Given this list of marker genes PEX2 (peroxisomal biogenesis factor 2), NSUN2, B3GAT3, SLC35A2, B3GALT6, ZBTB20, WDR26, DHCR24, MEG3, NALCN, GUSB, FGD1, SOX9, UBE3B, FIG4, FGFRL1, TNNT3, TNNI2, TRPV4, MYH8, CHST3, VAC14, RAB23, DDR2, RAB3GAP2, SLC26A2, FBN1, SH3PXD2B, ZFX, RTL1, PEX1, TUBB3, FIBP, FBN2, CTBP1, LMNB2, NSD2, MAPK1, PIEZO2, CPLX1, LETM1, DHCR7, UBAP2L, DLK1, PEX5, GLI3, SKI, EZH2, XYLT1, LIG4, MET, WNT7A, here is a description of the gene set: Human Gene Set: HP_METATARSUS_ADDUCTUS Metatarsus adductus species: Homo sapiens The metatarsals are deviated medially (tibially), that is, the bones in the front half of the foot bend or turn in toward the body.